Given this list of marker genes IKBKB, NFKBIA, TRADD, CHUK (NCBI Gene Id 1147), NFKB1 (nuclear factor kappa B subunit 1), RELA, IKBKG, TRAF6, TAB1, MAP3K7, TAB2, here is a description of the gene set: Pathway Definition from KEGG: LMP1 -> (TRADD+TRAF6) -> (TAB1/2+TAK1) -> IKK -> NFKBIA -> NFKB studied in species Homo sapiens EBV LMP1 to NFKB signaling pathway. Pathway ID: N00265. Pathway type: Pathogen. Pathway class: nt06516 TNF signaling. Human Gene Set: KEGG_MEDICUS_PATHOGEN_EBV_LMP1_TO_NFKB_SIGNALING_PATHWAY